Given this list of marker genes CRY1, RHOQ, ITGB1, ZNF28, MBD4, CCDC77, CPSF6, TCF21, PPM1L, RELT, KPNA5, PPP1R7, SLC5A1, COPS6 (COP9 signalosome subunit 6), KIAA0040, MMP24, NUP98, PRLR, CLEC1A, MBNL1, CLCC1, CDNF, KLHL14, SLC30A4, TMEM248, ACSBG1, ZFPM2, BNC2, CLDN16, GRIK2, SDC3, PIK3C2A, ZMAT5, GYPE (glycophorin E (MNS blood group)), OSMR, REPS1, PROP1, XCL1, RNF103, CEP41, ANKRD50, TOMM7, TMPRSS11A, C1orf115, EPOR, CEP85L, GLDN, RAB27A, SYNM, ERCC6, SLC25A34, MS4A2, SLC4A4, TCHP, ITGA9, ZNF711, KRAS, USP9X (ubiquitin specific peptidase 9 X-linked), TESMIN (testis expressed metallothionein like protein), PLD1, NT5E, RMND5A, PLCH1, MMRN1, PDCD7, LVRN, ZNF561, SLC25A5, NSUN5, KRT12, TBC1D7, RIMS2, MOSPD1, here is a description of the gene set: studied in species Homo sapiens from publication Chen Y, Wang X (PMID 31504780) Human Gene Set: MIR134_5P Genes predicted to be targets of miRBase v22 microRNA hsa-miR-134-5p in miRDB v6.0 with MirTarget v4 prediction scores > 80 (high confidence targets).